The following is a description of a gene set: species: Homo sapiens A tooth crown with its mesial and distal sides converging or tapering toward the incisal edge causing severe reduction of mesiodistal diameter Peg-shaped maxillary lateral incisors Human Gene Set: HP_PEG_SHAPED_MAXILLARY_LATERAL_INCISORS, and this is the list of marker genes: KAT6A, CDH1, AXIN2, WNT10B, NECTIN1, DLG1, IRF6, EDA, PDGFRA, COBLL1, EDARADD, TP63, SUMO1, LRP6, ARHGEF38, BMP4, NEK1, PAX9, FGF3, DLX4, MSX1, TGFA, FGFR1, NAA80, ARHGAP29, WNT10A, RIC1